The following is a description of a gene set: part of: N-glycan trimming in the ER and Calnexin/Calreticulin cycle Reactome Pathway: Calnexin/calreticulin cycle species: Homo sapiens The unfolded protein is recognized by a chaperon protein (calnexin or calreticulin) and the folding process starts. The binding of these protein requires a mono-glucosylated glycan (Caramelo JJ and Parodi AJ, 2008) and lectin-based interaction with client proteins is the predominant contributor to chaperone activity of calreticulin (inferred from the mouse homolog in Lum et al. 2016)., and this is the list of marker genes: EDEM1, OS9, PDIA3, CANX, MARCHF6, UGGT1, RNF185, RNF139, RPS27A, RNF5, UBC, UBA52, TRIM13, CALR, DERL2, RNF103, PRKCSH, EDEM2, UBB, AMFR, SYVN1, SEL1L, UGGT2, MAN1B1, GANAB, EDEM3